Given this list of marker genes Dpp4, C5ar2, Slit2, Slamf8, Tnfaip6, here is a description of the gene set: Mouse Gene Set: GOBP_NEGATIVE_REGULATION_OF_NEUTROPHIL_MIGRATION species: Mus musculus Any process that stops, prevents or reduces the frequency, rate or extent of neutrophil migration.